Given this list of marker genes ZMYM3, PLCG1, KLF11, OGG1, CELSR2, PRKAR2A, ELK1, COIL, PTPRS, TRAF6 (TNF receptor associated factor 6), here is a description of the gene set: Genes up-regulated in bone marrow hematopoietic stem cells (HSC, CD34+) from patients with high risk of myelodysplastic syndrome (MDS) compared with healthy controls. Gene patterns of expression in purified CD34(+) bone marrow cells from 7 patients with low-risk myelodysplastic syndrome (MDS) and 4 patients with high-risk MDS were compared with expression data from CD34(+) bone marrow cells from 4 healthy control subjects. CD34(+) cells were isolated by magnetic cell separation, and high-density oligonucleotide microarray analysis was performed. For confirmation, the expression of selected genes was analyzed by real-time polymerase chain reaction. Class membership prediction analysis selected genes. Using the expression profile of these genes, we were able to discriminate patients with low-risk from patients with high-risk MDS and both patient groups from the control group by hierarchical clustering (Spearman confidence). The power of these genes was verified by applying the algorithm to an unknown test set containing expression data from 8 additional patients with MDS (3 at low risk, 5 at high risk). Patients at low risk could be distinguished from those at high risk by clustering analysis. In low-risk MDS, we found that the retinoic-acid-induced gene (RAI3), the radiation-inducible, immediate-early response gene (IEX1), and the stress-induced phosphoprotein 1 (STIP1) were down-regulated. These data suggest that CD34(+) cells from patients with low-risk MDS lack defensive proteins, resulting in their susceptibility to cell damage. In summary, we propose that gene expression profiling may have clinical relevance for risk evaluation in MDS at the time of initial diagnosis. Furthermore, this study provides evidence that in MDS, hematopoietic stem cells accumulate defects that prevent normal hematopoiesis. from publication Hofmann WK, de Vos S, Komor M, Hoelzer D, Wachsman W, Koeffler HP (PMID 12411319) Human Gene Set: HOFMANN_MYELODYSPLASTIC_SYNDROM_HIGH_RISK_UP studied in species Homo sapiens